The following is a description of a gene set: Mouse Gene Set: TABULA_MURIS_SENIS_SUBCUTANEOUS_ADIPOSE_TISSUE_MESENCHYMAL_STEM_CELL_OF_ADIPOSE_AGEING from publication Tabula Muris Consortium (PMID 32669714) species: Mus musculus, and this is the list of marker genes: Cdv3, Rras, Btg2, Prrx1 (NCBI Gene Id 98443), Palm, Mxra7, Ddrgk1, Nfic, Anxa8, Dtnbp1, Klf2, Norad, Nr3c1 (nuclear receptor subfamily 3, group C, member 1), Kdm6b, Adam33, Cd74, Mmp11, Clic1, Bgn, Ebf1, Samd4b, H2-Ab1, Pltp, Tnfsf12, Rbp1, Dact1, Midn, Nbl1 (NCBI Gene Id 17965), Fdps, Rabac1, Ptov1, Gnaq, Igfbp3, Rbm25, Cotl1, Ralbp1, Ptgs1, Zfp36 (NCBI Gene Id 22695), Jund, Ramp2, Akap12, Atp6v0c, Cyba, Osr1 (odd-skipped related transcription factor 1), Dact2 (dishevelled-binding antagonist of beta-catenin 2), Ubl7, Zfhx3 (NCBI Gene Id 68160), Tamalin, Cavin1, Nudt3, Prnp, Nsd3, Bcl7c, Fosl2, C1qc, Gsk3b, Cygb, Akt1s1, Sod1, Gadd45g, Iigp1, Aif1l, Myoc, Fbln2, Srsf11, Znhit1, Gata3, Tle5, Sf3b2, Selenom (selenoprotein M), Xist, Ubb-ps, Nsg1, Ap2s1, Hspa1a, Bri3, Dhrs3, Tgfbi, Fbln1 (NCBI Gene Id 14114), Thbd (NCBI Gene Id 98935), Ifitm2, Gstm1, Sptbn1, Tcf7l2, Gas7, Pdpn, Ier3, Fus, Phlda1, Mrgprg, Lrrc8a, Dusp3, Ywhae, Pmepa1, Tmem160, Ccdc85b, Apbb1ip, Tmem176b, Fos, Ddah2, Rhoc, Rhob, Dmkn, Arf5, Ltbp4, Il3ra, Oaz1, Ctss, Itgb7, Camk2n1, Fxyd1, Skil, Cdkn1c, Atn1, Aebp1, Rpl13a (ribosomal protein L13A), Reep5, Capg, Mllt6, Rack1, Clic4, Arhgdia, Tmem176a, Gadd45b, Ier2, Crispld2, Ndrg2, Nfix, Gpnmb (glycoprotein (transmembrane) nmb), Rarg, Cfl1, Arl8a, C1qb, Mn1, Chst1, F3, Cd9, Ado, Nr4a1, Ptp4a2, Selenow (selenoprotein W), Apod, Fcrl2, Pcnp (PEST proteolytic signal containing nuclear protein), Hic1, Map1lc3a, Il34, Tppp3 (tubulin polymerization-promoting protein family member 3), Grina, Fxyd5, Scand1, Mir24-2, Klf13, Nabp2 (nucleic acid binding protein 2), Vat1, Gpx3 (NCBI Gene Id 14778), Lrrc58, Clu, Mgp, Cdc37, Ptms, Tacc1, Tmem9, Hmgcs1, Marcks, Nfib, Rbm26, Lyz2, Selplg, Sparcl1, Tcf7l1, Rarres2, Cst3, Gabarapl1, Mospd3, C1qa, Ecm1, Bmp3, Adamtsl3, Gadd45gip1, Gpx4 (NCBI Gene Id 625249), Sfrp1, Klf9, Srsf2, Msx1, Sdc4, Emc10, H2-Aa, Tex261, Clec3b, Chmp2a (NCBI Gene Id 68953), Spr, Senp6, Ube2m, Tmsb10, Pdlim2, Letm2, Chd4, Mycbp2, Junb, Phlda3, Ssbp3, Mfge8, Crip2, Scn1b, Pebp1, Prr13, Txn2, Cdkn1a, Lmna, Fkbp8, Zscan26, Lifr, Set, Basp1 (NCBI Gene Id 70350), Dpt, C4b, Rab5c, Ptma, Cirbp, Ssbp4, Bsg, Szrd1, Plpp3, Srrm2 (NCBI Gene Id 75956), Ctnna1, Tomm6, Drap1, Ypel3, Jun, Apoe (apolipoprotein E), Cxcl12, Dpysl2, Inmt, Tra2a, Gnb1, Adrm1, Gbp7, Srsf5, Dlgap4, Ube2v1, Shisa5 (shisa family member 5), Sf3b4, Cfh, Krt14, Wbp2, Anapc11, Irf2bpl, Cxcl14, Penk, Mafb, P2ry12, Snrpc, Lamtor4, Ece1, Zfp385a, Manbal, Kpna4, Timp3, Akap13, Csnk2a1, Ftl1